The following is a description of a gene set: Genes predicted to be targets of miRBase v22 microRNA hsa-miR-3173-3p in miRDB v6.0 with MirTarget v4 prediction scores > 80 (high confidence targets). from publication Chen Y, Wang X (PMID 31504780) Human Gene Set: MIR3173_3P studied in species Homo sapiens, and this is the list of marker genes: OXSR1, CLUL1, EN2, PCDH19, PRRC2B, RTKN2, PICALM, RAB8A, CDYL2, CORO2B (coronin 2B), YIPF6, CNOT6L, MEF2D, KMT2A, EPM2AIP1, AUNIP, HNRNPH1, RGPD8, ARID1A, CLCN3, G6PC1, CD55, SLC9A5, FAM83A, PIM1, LGI2, KAZN, RETREG3, FRYL, HYAL4, NRM, PPP6C, NWD2, TBC1D10A, SLC25A35, SEMA3F, C2CD5, RGPD5, JCAD, ATP6V1A, CELF4, LRRC70, PTGER3, RELN, MECP2, EPHA7, FBP1, SNX16, PPP1R16B, RBIS (NCBI Gene Id 401466), GMFB, PRTG, RUNDC3B, NUFIP2, USP32, ZPBP2, SPOCK1, ZNF444, TOB1, ZBTB7A, GSPT1, SLC24A4, OSM, APH1A, MTCL2, ABLIM3, TMEM35B, PRH2, ARMC7, STK40, MCU, ZKSCAN1, MYO6, MIB1, SORCS1, RGPD6, FHIP1A, PYCR2, ZNF333, CHD4 (chromodomain helicase DNA binding protein 4), MYO1D, PRR13, NOVA2, DNA2, APOBEC3H, CEP170, FCHSD2, COBL, KAT6A, ZDHHC9, SARM1, MAL2, CD38, RIMS3, RNF5, TAOK1, LCE2C, SMG5, TOPORS, SHISA6, VAMP1, UBE2Q1, PLEKHS1, SON (NCBI Gene Id 84155), MAX